Given this list of marker genes BMPR2 (NCBI Gene Id 659), DLL4, HEY2, MESP1, WNT2, SHOX2, ACVR1, ENG, GJA5, TGFB2, GATA4, MYH6, NOTCH1, TBX5, ISL1, HEG1, NKX2-5, SOX4, NSD2, CCN1, SMO, BMP2, PROX1, TBX20, NOTCH2, NOG, PITX2 (NCBI Gene Id 5308), ZFPM1, BMP10, SOS1, here is a description of the gene set: The process in which the cardiac atrium is generated and organized. A cardiac atrium receives blood from a vein and pumps it to a cardiac ventricle. Human Gene Set: GOBP_CARDIAC_ATRIUM_MORPHOGENESIS studied in species Homo sapiens